The following is a description of a gene set: Genes that have low expression in mammary tumors of microacinar histology. from publication Hollern DP, Swiatnicki MR, Andrechek ER (PMID 29346386) Human Gene Set: HOLLERN_MICROACINAR_BREAST_TUMOR_DN species: Mus musculus Human breast cancer has been characterized by extensive transcriptional heterogeneity, with dominant patterns reflected in the intrinsic subtypes. Mouse models of breast cancer also have heterogeneous transcriptomes and we noted that specific histological subtypes were associated with particular subsets. We hypothesized that unique sets of genes define each tumor histological type across mouse models of breast cancer. Using mouse models that contained both gene expression data and expert pathologist classification of tumor histology on a sample by sample basis, we predicted and validated gene expression signatures for Papillary, EMT, Microacinar and other histological subtypes. These signatures predict known histological events across murine breast cancer models and identify counterparts of mouse mammary tumor types in subtypes of human breast cancer. Importantly, the EMT, Adenomyoepithelial, and Solid signatures were predictive of clinical events in human breast cancer. In addition, a pan-cancer comparison revealed that the histological signatures were active in a variety of human cancers such as lung, oral, and esophageal squamous tumors. Finally, the differentiation status and transcriptional activity implicit within these signatures was identified. These data reveal that within tumor histology groups are unique gene expression profiles of differentiation and pathway activity that stretch well beyond the transgenic initiating events and that have clear applicability to human cancers. As a result, our work provides a predictive resource and insights into possible mechanisms that govern tumor heterogeneity., and this is the list of marker genes: SYNPO, STEAP1, ARMCX4, TNC, WNT5B, SLC16A1, DRAM1, PTPRS, ACKR3, PTGES, TNFAIP2, ADAMTS5 (ADAM metallopeptidase with thrombospondin type 1 motif 5), HPGD, ST6GAL1, TUBB2B